Given this list of marker genes RELA (RELA proto-oncogene, NF-kB subunit), SQSTM1, PRKCZ, SMPD1 (NCBI Gene Id 6609), FADD, RFFL, MAP3K3, MAP4K3, MAP4K2, TNF, ADAM17, IKBKB, PRKCI, CYLD, TNFRSF1A, TRAF1, NRK, NSMAF, BIRC3, RIPK1, MAP4K4, MAP3K5, MAP2K3, TRAF2, CASP8, MAP3K7, MADD, TNFRSF1B, MAP4K5, BAG4, BIRC2, CHUK, TXN, NFKB1, TAB2, CAV1 (NCBI Gene Id 857), MAP2K7, TNIK, TRADD, MAP3K1, TNFAIP3, SMPD2, TAB1, RACK1, IKBKG (NCBI Gene Id 8517), STAT1, here is a description of the gene set: studied in species Homo sapiens TNF receptor signaling pathway from publication Schaefer CF, Anthony K, Krupa S, Buchoff J, Day M, Hannay T, Buetow KH (PMID 18832364) Human Gene Set: PID_TNF_PATHWAY